The following is a description of a gene set: Mouse Gene Set: GOMF_PHOSPHOLIPASE_A1_ACTIVITY species: Mus musculus Catalysis of the reaction: a 1,2-diacyl-sn-glycero-3-phosphocholine + H2O = a 2-acyl-sn-glycero-3-phosphocholine + a fatty acid + H+., and this is the list of marker genes: Lpl, Abhd3 (NCBI Gene Id 106861), Pnliprp2, Pnpla8, Pla1a, Plaat3, Plaat5, Pla2g4b, Lipg, Plaat1, Pla2g15, Pnliprp1, Ddhd1, Pnlip, Lipc